The following is a description of a gene set: Mouse Gene Set: GOBP_POSITIVE_REGULATION_OF_NEURAL_PRECURSOR_CELL_PROLIFERATION Any process that activates or increases the frequency, rate or extent of neural precursor cell proliferation. studied in species Mus musculus, and this is the list of marker genes: Ctnnb1 (NCBI Gene Id 12387), Trf, Gli3, Cdon, Lyn, Id4, Ryk, Adgrg1, Sox2, Hdac5, Egf, Gjc2, Itgb1, Ngfr, Ascl1, Lrp2, Nap1l1, Ctf2, Cip2a, Aspm, Sbno1, Vegfa, Tox, Smo, Zfp335, Pitx3, Nrg1, Fgf2 (NCBI Gene Id 14173), Mup20, Wnt3a, Prox1, Kdm1a, Erbb2, Mdk, Fzd3, Gpr37l1, Pax6, Gnai2, Shh, Rsu1 (Ras suppressor protein 1), Cx3cl1, Dct, Dmrta2, Hif1a, Foxg1, Drd2, Mapk8, Otp, Igf1, Dll4, Nr2e1, Disp3, Bex1, Fzd9, Notch1, Gng5, Setd1a, Vegfc, Sox10, Insm1, Prl2c2, Disc1, Gak, Ell3, Smarcd3, Rassf10, Cx3cr1, Nog (NCBI Gene Id 18121), Wdr62, Lhx2, Flna, Optn, Nes